The following is a description of a gene set: Mouse Gene Set: GOBP_POSITIVE_REGULATION_OF_LYMPHOCYTE_ANERGY species: Mus musculus Any process that activates or increases the frequency, rate, or extent of lymphocyte anergy., and this is the list of marker genes: Foxp3, Lilrb4b, Lilrb4a, Cd3e, Itch, Nr5a2, Cblb